The following is a description of a gene set: Any process that modulates the frequency, rate or extent of RNA polymerase II transcriptional preinitiation complex assembly. species: Homo sapiens Human Gene Set: GOBP_REGULATION_OF_RNA_POLYMERASE_II_TRANSCRIPTION_PREINITIATION_COMPLEX_ASSEMBLY, and this is the list of marker genes: WNT10B, CREB1, HMGB1, THRA, TP53, PSMC6, CAND1